The following is a description of a gene set: Human Gene Set: GOMF_MRNA_REGULATORY_ELEMENT_BINDING_TRANSLATION_REPRESSOR_ACTIVITY species: Homo sapiens Antagonizes the ribosome-mediated translation of mRNA into a polypeptide via direct binding (through a selective and non-covalent interaction) to nucleic acid., and this is the list of marker genes: IREB2, RARA, DHFRP1, PAIP2, PAIP2B, SHMT1, CPEB4, CPEB2, CPEB1, CELF1, CELF4, ACO1, CPEB3, PURB, PURA, ZNF540, DHFR, TYMS